The following is a description of a gene set: studied in species Mus musculus The formation of mature insulin by proteolysis of the precursor preproinsulin. The signal sequence is first cleaved from preproinsulin to form proinsulin; proinsulin is then cleaved to release the C peptide, leaving the A and B chains of mature insulin linked by disulfide bridges. Mouse Gene Set: GOBP_INSULIN_PROCESSING, and this is the list of marker genes: Pcsk2, Ero1b, Ins2, P4hb, Slc30a5, Hsp90b1, Pcsk1, Yipf5, Cpe, Hid1, Slc30a8